Given this list of marker genes IFI35, LHX3, CYRIA, CCNG2, MAD2L2, PMS2P1, BHLHE41, H2AC18 (H2A clustered histone 18), PTPRS, GTPBP3, HLA-DPA1, ATG16L1, CARD16, RPS5, DMD, MAP3K2, PYROXD1, SLC12A4, BMP6, GAS2, FGF13, CYTH1, TGFB3, PCTP, C2, PSMA3, MAP3K10, BOD1L1, NUMA1, DDX18, PTHLH (NCBI Gene Id 5744), GCHFR, GRK5, LIMK2, CEBPD, GEMIN7 (gem nuclear organelle associated protein 7), THEMIS2, DHRS3, SYNGR1, PNLIPRP1, CXCL10, RPL24, DCAF10, HSPA1B, RDX, KCND1, PCCB, FERMT2, PFKFB3, ANXA4, JUND, MYO5B, ACSL3, ZNF292, NBPF3 (NCBI Gene Id 84224), SRP72, DNAAF8, OSGIN2, SNX14, LBP, SNX2, GCLM (NCBI Gene Id 2730), PCDH1, RNF139 (ring finger protein 139), SKIC2, PRKAR2B, FLI1, FUZ, RAB3GAP2, TRIM33, SYT1, CCT6A, KIF13A, AK3, ARPP19, PLPP3, COL4A5, RHOH (ras homolog family member H), LZTR1, MCTS1, RPL13 (NCBI Gene Id 6137), ARPC5, DSCC1, CISH, TMEM143, FLVCR1 (FLVCR choline and heme transporter 1), NDP, DSG2, TFAP2B, ZNF587, AAGAB, LLPH, HOXD8, GCGR, MIEN1, DDX11, NOL7, YPEL3, ATXN3, CCNB1, ESYT2, FRMD4A, PLCL1, PILRB, SINHCAF, SIL1, CPA2, TRDN, AKAP5, F7, SDHC (NCBI Gene Id 6391), CRBN, BPHL (NCBI Gene Id 83355), SMARCA5, ZEB1, PRSS1, DHX34, GRIN2C, TIMP1, SPOCK2, RERE, DUSP4, SZRD1, S100A12, FRG1, RPS18, GALC, PPP1R11, DLX5, KRT19, ALG13, SLC5A1, WNT3A, SERPINB5, BET1L, ZNF224, SYK, ENOX1, LEP, GABRE, SP110, MAP4K2, CLSTN3, PSEN1, AP1S1, HS6ST1 (heparan sulfate 6-O-sulfotransferase 1), DDX17, NUP210, BAIAP2, SOX2, DNAJC9, TRIP4, SERPINA3, ATE1, VAV2, MBD5, PRG2, FOSL2, SNED1, DPP6, LGALS8, CACNA1C, ERCC3 (ERCC excision repair 3, TFIIH core complex helicase subunit), SRPRB, DNAJB1, OSBPL2, here is a description of the gene set: Genes in the cancer module 334. studied in species Homo sapiens Human Gene Set: MODULE_334